The following is a description of a gene set: from publication Ibrahim L, Mesgarzadeh J, Xu I, Powers ET, Wiseman RL, Bollong MJ (PMID 33096892) Transcripts up-regulated in HEK293T cells overexpressing FLAG-NRF3 Human Gene Set: IBRAHIM_NRF3_UP studied in species Homo sapiens The NRF transcription factors NRF1, NRF2, and NRF3, are a subset of Cap'n'collar transcriptional regulators which modulate the expression of genes harboring antioxidant-response element (ARE) sequences within their genomic loci. Despite the emerging physiological importance of NRF family members, the repertoire of their genetic targets remains incompletely defined. Here we use RNA-sequencing-based transcriptional profiling and quantitative proteomics to delineate the overlapping and differential genetic programs effected by the three NRF transcription factors. Comparing our data to recent profiling analyses, we create consensus target gene sets regulated by NRF1, NRF2, and NRF3, genetic programs which we determine to be differentially regulated in human tissues. Together, our data provide a quantitative assessment of how NRF family members sculpt proteomes and transcriptomes, essential information for future studies evaluating the role of NRF factors in normal physiology and disease., and this is the list of marker genes: BLOC1S5-TXNDC5, CMAS, GCLM, PSMD4, HMOX1, RPN2, ANKRD20A3P